Given this list of marker genes Chka, Alox15, Chkb, Etnk1, Pisd, Etnk2, Cept1, Selenoi, Pcyt2, Slc27a1, here is a description of the gene set: Mouse Gene Set: GOBP_PHOSPHATIDYLETHANOLAMINE_BIOSYNTHETIC_PROCESS The chemical reactions and pathways resulting in the formation of phosphatidylethanolamine, any of a class of glycerophospholipids in which a phosphatidyl group is esterified to the hydroxyl group of ethanolamine. studied in species Mus musculus